Given this list of marker genes Kcnj3, Kcnj9 (potassium inwardly-rectifying channel, subfamily J, member 9), Kcnj6, Kcnk1, Kcnj5, Kcnh2, here is a description of the gene set: studied in species Mus musculus Mouse Gene Set: GOCC_INWARD_RECTIFIER_POTASSIUM_CHANNEL_COMPLEX A protein complex which is capable of inward rectifier potassium channel activity.